The following is a description of a gene set: Posteriorly rotated ears Human Gene Set: HP_POSTERIORLY_ROTATED_EARS studied in species Homo sapiens A type of abnormal location of the ears in which the position of the ears is characterized by posterior rotation (the superior part of the ears is rotated towards the back of the head, and the inferior part of the ears towards the front)., and this is the list of marker genes: ANKRD11, CTNND2, KCNH1, HBA2, CANT1, DNAJC30, MYMX, CHD5, CTBP1, KAT6B, GPRASP2, FKBP6, ESAM, DLK1, SOS2, CDC42, RMRP, B3GLCT, SMPD4, UMPS, MAGEL2, PEX26, MESD, MID1, TMEM231, BRAF, BAZ1B, OCRL, BBIP1, RPGRIP1L, SMAD2, FGD1, KDM4B, PDE6D, SMC1A, ZC4H2, CPLANE1, COG5, DHODH, B9D2, BBS9, FN1 (fibronectin 1), NRCAM, SOX5 (SRY-box transcription factor 5), RNU4ATAC, KIF7 (kinesin family member 7), POMT1, ALX3 (NCBI Gene Id 93575), PEX2, GMNN, TCTN1, TRPS1, TAF6, HDAC8, POMK, PIGS, IFT140, COG1 (component of oligomeric golgi complex 1), GPC3, CEP57, POLR1D (RNA polymerase I and III subunit D), CDK10, MYOD1, SCLT1, MAPRE2 (microtubule associated protein RP/EB family member 2), ZEB2, TOPORS, ATN1, RAF1, RAPSN, MAB21L1, CDH2, PTPN11, KIAA0753, TBX15, CEP290, KCNAB2, NAA20, AP1G1, TCF20, SCAPER, FBN1 (NCBI Gene Id 7470), DOK7, ARID2, KMT2D, IFT172, GALNT2, PEX12, PEX11B, SIAH1, TRIP13, OFD1, CHD7, CHMP1A, AP3B1, PIGG, DHX16, PSMD12, COL11A2, RAP1B, LFNG, TCOF1, MYCN, PEX3, CASZ1, IFT74, PEX6, HOXD13, RFC2, TBL1XR1, RFX7, ASXL2, PDPN, MN1, SMG9, POMGNT2, SLC25A24, PDE4D, PPP1CB, CFAP418 (cilia and flagella associated protein 418), KCTD1, MEG3, MAP3K7, ADAMTS18, SUZ12, SATB1, GPC4, FRMD4A, EIF4H, OTX2 (NCBI Gene Id 5015), GABRD, MAF, DHX30, AFF4, BBS7, TMEM165, CDT1, TBR1, NIPBL, SOD1, TMEM216, TMEM107, H4C9, FREM1, WDPCP, TTC8, SMC3 (NCBI Gene Id 9126), MUSK, XYLT1, EXOSC2 (exosome component 2), PHOX2B, CSGALNACT1, TBCE, BUB1, SATB2, HUWE1, METTL27, FAM20C, ZMYM2, PIGU, BCL11B, COL4A1, SUPT16H, ACAN, TRRAP, RALA, QARS1, RIT1, RAD21, DHCR7, CDC6, PIGN, HOXB1, MAP2K1, GLE1 (GLE1 RNA export mediator), PPM1B, KIAA0586, CSPP1, KAT6A, PRKAR1B, WAC, NOTCH3, PRKCZ, ZNF148, RRAS2, ORC4, FHL1, HYLS1, NUP88, DVL1, CDC45, POGZ, FLNA (filamin A), RIPPLY2, RTL1, STX1A, SPOP, MITF, ASCC3, TXNDC15, SEMA5A, LIMK1 (LIM domain kinase 1), CEP41, FBXO11, PRDM16, MKS1, MVK, RRAS, ORC1, TRIM32, MEGF8, ELN, PIGV, RAB18 (NCBI Gene Id 22931), SF3B4, YY1 (NCBI Gene Id 7528), POC1A, B9D1, NSDHL, PAX3, NPHP1, ALG9, COX7B, ERCC1, SLC18A3, POMGNT1, SRCAP, NR4A2, SPRED2, VPS37D, PEX13, EZH2, FOXE1, B3GALNT2, ITCH, FGFR2, LIG4, RBM8A, RAB3GAP1, CRELD1, TBC1D20, KRAS, BLTP1, PEX5, EBF3, MAP1B, UNC80, TAF4, ESCO2, RTTN, TMEM67, SMG8, BBS5, NELFA, SIX2, ACTG2, EBP, BMP4, OTUD5, INPPL1 (NCBI Gene Id 3636), TMEM138, FKTN, LUZP1, PEX1, PEX19, GBA1, CHST14, SHOC2, NF1, BBS1, DHCR24, SCARF2, IPO8, B3GALT6, B4GAT1, TLK2, PREPL, LRP2, PLCB4, CC2D2A, MRAS, ANKH, HERC1, HBA1 (hemoglobin subunit alpha 1), FAM149B1, GTF2I, GNAI3, SEMA3E, DAG1, EIF3F, CLIP2, TUBB, TCTN3, FRA10AC1, CAMTA1, DIS3L2, MESP2, TFAP2A, PIEZO2, SLC3A1, DSE, ERI1, EXT1 (exostosin glycosyltransferase 1), SOX11, GPT2, RXYLT1, GTF2IRD1, ADNP, POLR1C, SLC26A2, SRRM2, TMEM237, CD96, DPF2, H3-3A, BBS10, SMOC1, CHD8, BBS2, TAPT1, MMP23B, XYLT2, CASP2, DDR2, GPX4, PLAA, SET, SDCCAG8, TMEM94 (NCBI Gene Id 9772), DLL3, SOX4, GLI3, C2CD3 (C2 domain containing 3 centriole elongation regulator), UBE4B, MBTPS1, SKI, SPRED1, ARID1B, UBAP2L, BBS4, HES7, BMP2, NRAS, POLR1B, KDM6A, CLCN3, RBM10, GRIP1, HSPG2, SMARCA2, TGDS, POLE, BICRA, CRPPA, ROR2, LZTFL1, ACTB, RECQL4, AHI1, CEP120, TMCO1, ARL6, RAB3GAP2, BUB3, LARGE1, RERE, RPS26, PPP2R3C, HS2ST1, FZD2, ZNF423, HRAS, IL6ST, BRD4, C1GALT1C1, NSRP1, BCOR, BBS12, MYH3, CBL, ALX1, POMT2, SNRPB, TBL2, MRPS22, NALCN, PNPLA6, TFE3, FLI1, METTL5, MGAT2, TUBA1A, RUSC2, ATRX, CAMKMT, RNU4-2, CDK13, MKKS, GLI2 (NCBI Gene Id 50806), ZNF699, TOGARAM1, RPS28, TMEM270, BUD23, AMER1, GTF2IRD2, TRPV4 (transient receptor potential cation channel subfamily V member 4), WNT5A, PUF60, FKRP, FDFT1, NSUN2, GNB1, PIGB (NCBI Gene Id 9488), EP300 (E1A binding protein p300), SLC4A10, ORC6, PYCR1, PEX10, RPGRIP1, CPLX1, CCNK, NSD1, PEX14, MAPK1, MRPS14, MAD1L1, RAI1, MPDZ, ASXL1, GPC6, HS6ST2, ECE1, POLR3A, INPP5E, DVL3, SPEN, RASA2 (RAS p21 protein activator 2), MRPS28 (NCBI Gene Id 64947), IFT27, SMARCD2, KMT2B, LZTR1, USP9X, FREM2, CEP19, ERMARD, BUB1B, PAX7, NXN, EDN1, NCF1, SOS1, SRY, MED12, CDH11, CTCF, PEX16, COL2A1, ZFX, CPT2, DRG1, TCTN2, FGFR1, LETM1, KIF21A, PRRX1, MAP2K2, NFIX (NCBI Gene Id 4784), FRAS1, ASXL3, NAA10, PPM1D, NSD2